Given this list of marker genes MKRN2, CEBPB, GABPB1, ANGPTL2, CCNB2, PRC1, HBB, C1S, PARVG, OXR1 (NCBI Gene Id 55074), C2orf76, DPF2, SRF, RCBTB2, LSP1, PIGF, BMPR2, TRIM24, SARS1, PIP5K1C, UNC5CL, TNF, PIGH, TMPO, YBEY (ybeY metalloendoribonuclease), WDR6, MRPL10, IRF2BP1, BSG, STEAP2, TRIM32, S100B, PABPC1L, SLC22A2, BCAS3, SPPL3, HM13, SGPL1, BCL7C, DNAI4, ALMS1, S100A6, FKBPL, RAB22A, MAP3K3, DPAGT1, OTOP1, TRDMT1, IMMT, TUBG1, ADAM9, MOB3C, RTKN2, CRTC3, MCUB, ALLC, TRAPPC6B, NSDHL, ZNF32, HEBP1, TLR7, CAST, GADD45A, LMNA, NRROS, PSAP, FAM168A, EXOC4, EML3, SLC25A19, PIGX, JKAMP, RORC, SLC22A5, YWHAG, MSH6, ZCCHC8, SART1, CD68, COMT, YWHAB, ADIPOR2, NXNL2, ASB3, HACD4, UBR5, PLEC, HSF1, SLC52A3, GEMIN8, ZNF560, DCLK2, UROS, ARID1A, ACLY, JUNB, CLCN4, DGKA, ZFP36L1, XRCC3, KAT7 (NCBI Gene Id 63437), RNF181, PYCR2, SERHL2, MTR, PROS1, B3GNTL1, CHERP, CS, NECAP2, TUBGCP4, KHDC3L, TNFSF10, FAH, CYB561A3, NSMCE2, RPN2, AAMDC, CENPJ, HDAC3, DENND1C, TMEM255A, ZBTB45, WRNIP1, CREB5, PHPT1, SELENOM, RAMP1, VAT1, RBM42 (RNA binding motif protein 42), PRKCSH (PRKCSH beta subunit of glucosidase II), BASP1, ACOT8, CALCOCO1, AIP, HYCC1, ALKBH6, AGFG1, FBXL17, PGLYRP2, DOCK3, OAS2, GPT, ATP6V1G1, PI4KB, HMOX2, TMCC1, MIEN1, SCAMP2, DNAAF5, UBAC2, ORMDL1 (NCBI Gene Id 94101), RAB20, SPAG7, ZNF771, PRR14, CDK2, PGLYRP1, ZBTB7A, DNTTIP1, FOLR1, XPR1, ABRACL, ZMIZ1, CLDND1, RASL11B, PARP4, CERS6, CD6, MRPS26, CREB1, PHF1, BRD2, PSME1, NMI, CORO1C, GPX4, GORASP1, HK1, TRIP12, PEX19, SSR3, MED19, UBE2V1, TRAF3IP3, OMA1, HIPK2, CLDN12, ELOVL1, IFI35, STAU2, DALRD3 (NCBI Gene Id 55152), TMC4, EPB41L2, IFT22, SH3BP4 (NCBI Gene Id 23677), PRXL2C, RPS6KA5, KPNA2, here is a description of the gene set: from publication Eisenbarth SC, Williams A, Colegio OR, Meng H, Strowig T, Rongvaux A, Henao-Mejia J, Thaiss CA, Joly S, Gonzalez DG, Xu L, Zenewicz LA, Haberman AM, Elinav E, Kleinstein SH, Sutterwala FS, Flavell RA (PMID 22538615) Nlrp10-deficient mice have a profound defect in helper T cell-driven immune responses. T cell priming is impaired due to a defect in the emigration of a dendritic cells from inflamed tissue and antigen transport to draining lymph nodes. DC chemotaxis to CCR7-dependent and independent ligands is intact in the absence of Nlrp10. Therefore to identify novel molecules potentially involved in Nlrp10-dependent DC function we used an unbiased gene array approach on Nlrp10-deficient BMDCs treated with or without LPS. species: Homo sapiens Genes up-regulated in dendritic cells in response to LPS: wildtype versus NLRP10 knockout. Human Gene Set: GSE36009_WT_VS_NLRP10_KO_DC_LPS_STIM_UP